The following is a description of a gene set: species: Homo sapiens A high-pitched whistling sound associated with labored breathing. Wheezing Human Gene Set: HP_WHEEZING, and this is the list of marker genes: SPEF2, DNAAF2, DNAH9, DNAAF3, CRLF1, DNAH11, DNAAF5, DNAI1, TTC12, CFAP74, NKX2-1, DNAAF4, HLA-DQB1, DNAJB13, RSPH4A, OFD1, MCIDAS, CCDC39, DNAAF6, NME5, HYDIN (NCBI Gene Id 84907), CCDC40, NOS1, NME8, DNAH5, BTK, CCNO, SCNN1A, CFAP300, SCNN1G, CFAP298, SPAG1 (NCBI Gene Id 6674), DNAAF11, CFAP221, RSPH1, ODAD1, DNAAF1, CFTR, RPGR, NEK10, DRC1, ODAD4, HLA-DQA1, DNAI2, AGR2, GAS2L2 (growth arrest specific 2 like 2), DNAH1, DNAL1, RSPH3, RSPH9, ZMYND10, FCGR3A, SCNN1B, ATP8B1, LRRC56, SERPINA1 (serpin family A member 1), FOXJ1, ODAD3, STK36, ODAD2, PRIM1